The following is a description of a gene set: from publication Chen Y, Wang X (PMID 31504780) Mouse Gene Set: MIR_669C_5P species: Mus musculus Genes predicted to be targets of miRBase v22 microRNA mmu_miR_669c_5p in miRDB v6.0 with MirTarget v4 prediction scores > 80 (high confidence targets)., and this is the list of marker genes: Zscan12, Pid1, Asf1a, Hsdl2 (NCBI Gene Id 72479), Tmem165, Mkx, Tyr, Fez2, Becn1, Bcor, Cxcl16, Ankib1, Nsd3, Vcan, Tdrd3, Kdm5b, Nup35, Sirt2, Naaladl2, Plpp3, Ccar1, Lrp1, Mkrn2os, Eif2ak3, Fnta, Foxl1, Sh3d19, Aldh9a1, Car1, Zfp24, Mcf2l, Ap3m1, Myocd, Mtmr10, Usp28, Fam185a, Galnt13, Capn7, Slc7a11, Prmt8, Tfpi, Agfg1, Gphn (gephyrin), Ift56, 2310002L09Rik, Stam, Dmd